The following is a description of a gene set: Human Gene Set: HP_CEREBRAL_BERRY_ANEURYSM Cerebral berry aneurysm studied in species Homo sapiens A small, sac-like aneurysm (outpouching) of a cerebral blood vessel., and this is the list of marker genes: PKD1, TGFBR3, THSD1, ANGPTL6, COL3A1, ENG